The following is a description of a gene set: studied in species Homo sapiens Human Gene Set: GOMF_CALCIUM_ION_TRANSMEMBRANE_TRANSPORTER_ACTIVITY Enables the transfer of calcium (Ca) ions from one side of a membrane to the other., and this is the list of marker genes: TMEM37, CACNA2D3, OPRM1, PKDREJ, TRPV4, CATSPER2, FKBP1A, TRPM4, SLC24A1, STIMATE, GRIN2D, GHITM, NALF1, CNGA3, SGK1, STIM2, RYR3, GRIN1, MICU1, ATP2B2, TMCO1, TRPV1, RYR2, MCOLN2, CATSPER3, CACNG2, NALF2, CACNA1G, CALHM3, CABP1, TRPC7, NRXN1, GRIN2A, P2RX4, ITGAV, SLC8A3, CACNG4, CUL5, PANX3, ATP2C2, TMBIM4, TSPAN13, GRM2 (glutamate metabotropic receptor 2), ITPR2, CACNA2D1, ORAI2, NRXN2, TRPV5 (NCBI Gene Id 56302), PKD1L3, ATP2B3, NCS1, PANX1, TMC1, CNGA2, TRPC4, GRIA1, HPCAL4, RYR1, GEM, ANO9, SLC8A1, TNNI3, NPY2R, TRPC6, NPY, TMC2, TRPC3 (NCBI Gene Id 7222, transient receptor potential cation channel subfamily C member 3), MCUB (mitochondrial calcium uniporter dominant negative subunit beta), CACNA1A, MCU, TRPV2, CALM3, CALHM1, CACNG5, RRAD, CACNA1C, TRPM7, GRIK3, CACNG8, CACNA1I, ORAI1, TPCN1 (two pore segment channel 1), ATP2A2, PRKCB, SRI, SLC30A1, CACNA2D4, CACNG3, TRPM1, CACHD1, PKD1L2, CATSPER4, PSEN1, RASA3, CACNA1E, CALM2, PKD2, GRIN3B, CABP4, CACNB4, CACNA1F, PHPT1, TRPC1, PRKG1, GSTM2, NOS1, SLC24A3, MICU2, GRIN3A, TSPOAP1, TMBIM6, PKD1L1, CACNG7, CABP2, CACNA1S, TMBIM1, CACNB1, ATP2B1, TRPC5, TRPV6, TMEM165, PDE4B, SLC24A4, CACNG1, MICU3, MCOLN1, SLC30A10, CNGA1, FKBP1B, TRPM8, P2RX1, GRINA, TRPA1, CACNB3, CACNA1B, CNGA4, TRPM3, CALM1, FAIM2, ATP2A1, TPCN2, SLC8B1, PKD2L1, PKD1, CHRNA7, GRIK2, BNIP1 (BCL2 interacting protein 1), SEC61A1, GPM6A, ITPR3, CACNA1H, SLC11A2, TRPV3, TRPM6, SLC24A2, ATP2A3, CHRNA10, MCOLN3, AMBP, GRM3, CACNG6, SGK3, REM2, ATP2C1, PDE4D, STIM1, CACNA1D, UCP3, YWHAE, CNGB1, LETM1, CATSPER1, CRISP1, REM1, TRPC4AP, SLC8A2, PKD2L2, GRIN2B, TRPM2, STX1A, CAV3, ITPR1 (inositol 1,4,5-trisphosphate receptor type 1), GRIA3, GRIK1, CHRNA9, ORAI3, CACNA2D2, CABP5, ATP2B4, C8orf44-SGK3, SLC24A5, CACNB2, PACSIN3